Given this list of marker genes APOA4, APOA1, APOE, SAR1B (NCBI Gene Id 56680), MTTP, APOC3, APOC2, APOB, P4HB, APOA2, here is a description of the gene set: species: Homo sapiens Reactome Pathway: Chylomicron assembly Chylomicrons transport triacylglycerol, phospholipid, and cholesterol derived from dietary lipid from the small intestine to other tissues of the body. Each chylomicron assembles around a single molecule of apolipoprotein B-48 which at the time the particle leaves the intestine and enters the lymphatic circulation is complexed with >200,000 molecules of triacylglycerol (TG), ~35,000 of phospholipid, ~11,000 of cholesterol ester, ~8,000 of free cholesterol, ~60 copies of apolipoprotein A-I, ~15 copies of apolipoprotein A-IV, and copies of apolipoprotein A-II. part of: Plasma lipoprotein assembly